The following is a description of a gene set: from publication Chen Y, Wang X (PMID 31504780) Mouse Gene Set: MIR_363_3P Genes predicted to be targets of miRBase v22 microRNA mmu_miR_363_3p in miRDB v6.0 with MirTarget v4 prediction scores > 80 (high confidence targets). species: Mus musculus, and this is the list of marker genes: Mast4, Cdca7l, Sgpp1, Chia1, Edem1, Adam10, Evx2, Nol4l (NCBI Gene Id 98957), Hand2, Dock9, Kat2b, Itga6, Ddx3y, Sfxn1, Npc1, Ubash3b, Ankrd44, Kifap3, Plekhm1, Ddc, Prkar1a, Nsd3, Itpr1, Rnf38 (ring finger protein 38), Ptger4, Paxbp1, Phlpp2, Tent4a, Nova1, Glra1, Xylt2, Klhl14, B3galt2, Fbn1, Luzp1, Ptpro, Robo1, Gnaq, Bltp1, Myo1b (myosin IB), Peak1, Golga4, Arrdc3, Fli1, Fosl2, Ddx3x, Glyr1, Dcaf6, Arrdc4, Slx4, Rfx1 (regulatory factor X, 1 (influences HLA class II expression)), Herc2, Baz2b, Asxl2, Spryd4, Dsc2, Hivep1, Grhl1, Fbxw7, Rgs17, Itga8, Scn8a, Gfpt2, Golga7, Tmem184b, P3h3, Foxn2, Col1a2, Ewsr1, Bcl2l11, Fnip1, Kcna1, Rnf4, Ldlrad4, Tulp4, Adam23, Trim36, Zfp287, Tob1, Acrv1, Lhfpl2, Dennd1b, Slc25a36, Adamtsl1, Golga1, Pten, Atxn1, Pcdh11x, Per2, 1810055G02Rik, Dnaaf9, Zeb2, Morc3, Hcn2, Appl1, Ppcs, Zfc3h1, Avl9, Ptprk, Ube2z (ubiquitin-conjugating enzyme E2Z), Bcl11a, Pdzd2, Pitpnm2, Wrnip1, Sh3pxd2a, Usp36, Slc38a2, Dynlt3, Rev3l, Bmpr2, Gpr180, Abhd13, Herpud2, Ago3, Tgif1, Ppp1r12c, Hnf1b, Klf4, Tbl1xr1, Col27a1, Dmxl1, Med19, Ssbp2, Isca1, Evi5, Greb1l, Nox4, Kmt5b, Fzd10, Itgav (integrin alpha V), Itprid2, Atxn3, Aggf1 (NCBI Gene Id 66549), Rbm27, Zfyve21, Rab3c, Sim2, Ccnjl, Cd69, Tpcn1, Flvcr2, Ptar1, Pcdh9, Cpeb2, Prrc2b, Fnip2, Tef, Pip5k1c, Snx13, Map2k4, Glce, Csmd3, Slc12a5, Bcat2, Hecw1, Zfp521, Eomes, Cadm2, Cdk16, Pkdcc, Mpp1, Rgs3, Slco6c1, Grp, Trio, Rhpn2, Gramd2b, Gsta5, Bsdc1, Xrn1, Insig1, Map1b, Gpc6, Cpeb3, Exoc5, Trak2, Fancm, Dpp10, Wasl, Dus2, Pitpna, Pik3cb, D16Ertd472e, Cpeb4, Adamtsl3, Btg2, Ube2w, Ikzf2, Atp7a, Ergic2, Fry, Adcy3, Elk4, Rbpj, Hipk3, Usp28, Slc25a32 (solute carrier family 25, member 32), Gsta2, Snap29, Phtf2, Ccnc, Tmem229a, Fkbp1a, Robo2, Prkar2b, Tsc1, Klhl29, Galnt14, Pp2d1, Jmy, Ppp1r37, Cldn11, Arf1, Hps6, Nsmf, Fhl2, Gla, Itga5, Klf2, Nefm, Arid1b, Dtx2, Cux1, Atrx, Ugp2 (UDP-glucose pyrophosphorylase 2), Wwp2, Lats2 (NCBI Gene Id 50523), Tmem87a, Adam19, G3bp2, Fhip2a, Otud4, Ric1, Cic, Aida, Cyp2d22, Cog3, Braf, Grip2, Pik3r3 (phosphoinositide-3-kinase regulatory subunit 3), Stk39, Pcolce2, Ttc9, Nckap5, Armc1, Mycbp2, Tob2, Ranbp9, Gata2, Pnisr, Nsmaf, Bahcc1, Sgk3, Gm5148, Nufip2, Mia3, Pcdh7, Fmn2, Cep41, Strn3, Lpin1, P2ry13, Pla2g10 (NCBI Gene Id 26969), Slc17a6, Tcf21, Trim65 (tripartite motif-containing 65), Dkk3, Dennd4b, Zdhhc5, Rsbn1, Zfp827, Iqgap2, Synj1 (synaptojanin 1), Fnbp4, Dnajb9, Myt1l, Gid4, Rab8b, Myo5a, Mapk8, Rad21, Srpra, Sox11, Man2a1, Mboat2, Slc24a3, Rbpms2, Gata6, A830018L16Rik, Daam1, Nlgn1, Syn2, Gnpda2, Nfyc, Lmbr1l, Fam20c, Jarid2, Gdf11, Ddhd1, B230219D22Rik, Ankrd28, Tbc1d12, Sertad3, Cnep1r1, Slc6a1, Osbpl8, Bcl11b, Wdfy3, Fcho2 (FCH domain only 2), Rassf3, Gpr158, Snapc1, Pcgf3